Given this list of marker genes Tlr1, Tlr6, Tlr4, Lbp, Ssc5d, Ly96, Scarb1, Nr4a1 (NCBI Gene Id 15370), Casp4, Tlr2, Trem2, Itgav (NCBI Gene Id 76358), Nod2 (NCBI Gene Id 338538), Tlr9 (toll-like receptor 9), here is a description of the gene set: Mouse Gene Set: GOBP_DETECTION_OF_MOLECULE_OF_BACTERIAL_ORIGIN species: Mus musculus The series of events in which a stimulus from a molecule of bacterial origin is received and converted into a molecular signal.